The following is a description of a gene set: studied in species Mus musculus Mouse Gene Set: GOBP_SPLICEOSOMAL_CONFORMATIONAL_CHANGES_TO_GENERATE_CATALYTIC_CONFORMATION Structural rearrangements of the spliceosome complex, containing RNA to be spliced, to generate a catalytic conformation., and this is the list of marker genes: Snrnp200, Isy1, Xab2, Yju2, Prpf18